Given this list of marker genes GRIK2, BRD2, RLF, AREG, MUC7, IFNA5, THBS1, ZNF202, PTGER3, FGF18, IL6ST, GPRC5B, PTK7, HEXIM1, IL11, RSAD2, TFEC, NR4A3, IFIT1, ZC3HAV1, RSRP1, RFPL3S, LCN2, TFRC, APOBEC1, PTGS2, ISG15, SOD2, MTMR7, PTPN11, UBE3A, IFIT3, IFIT2, TACR3, RIPK1, PMAIP1, POLG2, CCT6B, PDE4D, COL4A6, CSRNP2, OASL, PCDH7, EYA2, ERVW-1, EFNB2, PMP2, FKBP5, B3GALT5, RBBP6, here is a description of the gene set: from publication Browne EP, Wing B, Coleman D, Shenk T (PMID 11711622) Genes up-regulated in primary fibroblast cell culture point after infection with HCMV (AD169 strain) at 4 h time point that were not up-regulated at the previous time point, 2 h. species: Homo sapiens The effect of human cytomegalovirus (HCMV) infection on cellular mRNA accumulation was analyzed by gene chip technology. During a 48-h time course after infection of human diploid fibroblasts, 1,425 cellular mRNAs were found to be up-regulated or down-regulated by threefold or greater in at least two consecutive time points. Several classes of genes were prominently affected, including interferon response genes, cell cycle regulators, apoptosis regulators, inflammatory pathway genes, and immune regulators. The number of mRNAs that were up-regulated or down-regulated were roughly equal over the complete time course. However, for the first 8 h after infection, the number of up-regulated mRNAs was significantly less than the number of down-regulated mRNAs. By analyzing the mRNA expression profile of cells infected in the presence of cycloheximide, it was found that a minimum of 25 mRNAs were modulated by HCMV in the absence of protein synthesis. These included mRNAs encoded by a small number of interferon-responsive genes, as well as beta interferon itself. Cellular mRNA levels in cytomegalovirus-infected cells were compared to the levels in cells infected with UV-inactivated virus. The inactivated virus caused the up-regulation of a much greater number of mRNAs, many of which encoded proteins with antiviral roles, such as interferon-responsive genes and proinflammatory cytokines. These data argue that one or more newly synthesized viral gene products block the induction of antiviral pathways that are triggered by HCMV binding and entry. Human Gene Set: BROWNE_HCMV_INFECTION_4HR_UP